Given this list of marker genes LBP, IKBKB, IFNB1, FCER1G, NFKB1, ITGAM, RHOA, CXCL10, RASSF5, AKT1, IRAK1, IRAK4, IRAK2, CHUK, MYD88 (MYD88 innate immune signal transduction adaptor), FGA, RELA, FGG, PLG, CD14, NOS2, IKBKG, TIRAP, TYROBP, TLR4, IRF3, PIK3CA, REL, TLR3, IL6, IL12B, TICAM2, SYK, TICAM1, LY96, CBLB, PLAT, CXCL3, CCL2, TNF, ITGB2, TRAF6, FGB, SRC, here is a description of the gene set: Fibrin complement receptor 3 signaling species: Homo sapiens Human Gene Set: WP_FIBRIN_COMPLEMENT_RECEPTOR_3_SIGNALING